Given this list of marker genes Mgat3, Chadl, Gm27825, Cyp2d36-ps, Adsl (NCBI Gene Id 11564), Xpnpep3 (NCBI Gene Id 321003), Maff, Sgsm3, Gm49537, Apol11b, Card10, Tef, Gm8221, Cdc42ep1, Mir5113, Polr3h, Gm36644, Xrcc6, Nol12, Tmem184b, Gm6612, Enthd1, Ift27, Aco2, Mrtfa, Lgals1, 4930407I10Rik, Gm20420, Cyp2d34, 8430426J06Rik, Cenpm, Tcf20, Serhl, Slc16a8, Mir1943, Tob2, Eif3d, Gm22107, Syngr1, Cby1 (NCBI Gene Id 73739), Cyp2d37-ps, Csnk1e, Apol10b, Tspo, Nptxr, Gm10856, Gm17638, Dnajb7, 4930588D02Rik, Pick1, H1f0, Cyb5r3, Mir7684, Cyp2d38-ps, Gm16059, Desi1, Mpst (NCBI Gene Id 246221), Gm24204, Scube1, Cyp2d22, Atf4, Gm46501, Gm25131, Rnu12, Ddx17, Srebf2, Cyp2d34-ps, Myh9, Tmprss6 (transmembrane serine protease 6), Gm16576, Rps19bp1, Elfn2, Polr2f, Gm23220, Cyp2d33-ps, A430088P11Rik, Micall1, Gm41361, 4930483J18Rik (NCBI Gene Id 67638), Gm17597, Gm18284, Apol7c, Arfgap3, 1110025M09Rik, Gcat, Dnal4, Poldip3, Txn2, Smim45, Gm31462, Kctd17, Il2rb (interleukin 2 receptor, beta chain), Cyp2d26, Tnfrsf13c, Gm3924, Ankrd54 (ankyrin repeat domain 54), Gm26634, Apobec3, Tab1, Grap2, A730060N03Rik, Cyp2d11, Snu13, Apol10c-ps, Gm36329 (predicted gene, 36329), Mir3080, Nfam1, Mei1, Gm28023, Baiap2l2, Naga, Pheta2, Mir6957, A4galt, Cacna1i, Slc25a17, Gm22067, Gm8375, Snord83b, Mpped1, Apol8, Gm17753, 1700041B01Rik, Cyp2d32-ps, Gm17025, Mchr1, Kcnj4, Ep300, Cyp2d12, Snord43, Gm36738, Bik, Zc3h7b, 1700027A07Rik, Gm5218, Apol7e, n-R5s41, Sun2, Csf2rb, Gga1, Gm31369, Josd1, Cyp2d41-ps, St13, Npcd, Gm5417, Septin3, Pdxp, Gm10863, Gm19267, Tomm22, Csf2rb2, Pmm1, Cyp2d35-ps, Eif3l, Gm32886, Gm46525, Gm46495, 1700088E04Rik, Gm19141, Galr3, 1700001L05Rik, Pacsin2, Kdelr3, Ndufa6, 1700025B11Rik, Cyp2d13, Tnrc6b, Apol10a, Ndufb11b, Smdt1, Rpl3, Cyp2d40 (NCBI Gene Id 71754), Foxred2, Sh3bp1, Shisa8, Pdgfb, Apol9b, Ccdc134, Rbx1, Gm8233, Ncf4, Csdc2, Gm20324, Wbp2nl, Rangap1, Pvalb, Mfng, Ttll12, 7530414M10Rik (NCBI Gene Id 320374), Mir6955, C1qtnf6, Cyth4, Gtpbp1, Gm5805, Cyp2d39-ps, Triobp, Cbx6, Mief1, Gm7318, Cyp2d10, Apol11a, Sstr3, Gm46524, Tst, Rrp7a, Fam227a, Rac2, Mcat, Mir33 (microRNA 33), Dmc1, Lgals1-ps2 (NCBI Gene Id 115488490), Cbx7, Gm36245, Gm6723 (predicted pseudogene 6723), Pla2g6, L3mbtl2, Sox10, Cacng2, Mir6956 (microRNA 6956), Mir7213, Cyp2d9, Gm8444, Gm18911, Tdg-ps (NCBI Gene Id 545124), Fam83f, Ttll1, Cyp2d67-ps, Cimip4, Lgals2, Phf5a, here is a description of the gene set: studied in species Mus musculus Mouse Gene Set: chr15E1